Given this list of marker genes Gnao1, Gnaz, Arrb2, Gnai1, Gnai3, here is a description of the gene set: Binding to a metabotropic serotonin receptor. Mouse Gene Set: GOMF_G_PROTEIN_COUPLED_SEROTONIN_RECEPTOR_BINDING species: Mus musculus